Given this list of marker genes QRICH1, EZH2, ACAN, TRPV4, CYP2R1, DDRGK1, B4GALT7, KIF22, FLNA, MATN3, POLR1A, TNFRSF11B, CFAP410, COMP, CHD7 (chromodomain helicase DNA binding protein 7), CUL7, PHEX, PTPN11, NANS, NSMCE2, PTH1R, CENPE, CCN2 (NCBI Gene Id 1490), TCIRG1, NPR2, RPL13, CRTAP, CLCN5, TINF2, EXOC6B, CSPP1, TERC, IL2RG, OCRL, CWC27, EIF2AK3, PLCB3, B3GALT6, GJA1 (NCBI Gene Id 7953), NOTCH3, IFT140, GPX4, EFL1 (elongation factor like GTPase 1), ALG9 (NCBI Gene Id 79796), POLE, SLC39A13, TMEM53, RASA1, LBR, NOTCH2, MAP3K7, EXT2, RNU4ATAC, NEK1, SFRP4, B3GAT3, ADA, LIG4, AMER1, SMAD4, LIFR, CHST3, ACVR1, EXT1, LPIN2, HDAC6, DNAJC21, FIG4, WRAP53, PCYT1A, NPM1, ARCN1, TRIP11, IFT122, BGN, BMP1, CCN6, COL11A1, AIFM1, SLC17A5, RAB33B, COL10A1, KCNE5, RB1, TONSL, DCLRE1C, LMBR1, LRRK1, CANT1, CLCN7 (chloride voltage-gated channel 7), MTAP, ANTXR1, TGFB1, PRKAR1A, SH3PXD2B, ABCC9, VPS33A, GNAS, NSD1, EXTL3, SLC29A3, IDH1, KCNJ8, PRKG2 (protein kinase cGMP-dependent 2), ATP7A, SETBP1, FBN1, ANKH, CTC1, IL7R, BMPR1B, GALNS, PEX7, DYNC2LI1, NHP2, SNRPN, TERT, RMRP (RNA component of mitochondrial RNA processing endoribonuclease), ACP5, IFT172, SNX10, TRPV6, DYNC2I2, RAB3GAP2 (NCBI Gene Id 26114), PISD, CEP120, PTDSS1, HNRNPH1, MAGEL2, TYMS, DNA2, AMMECR1, UFSP2, P4HB, OBSL1, COG4, RAG2, RUNX2, HSPG2, WDR26, ANAPC1, ALPL, IDH2, ALG3, GNPTAB, CTNS, LRP5, EED, DYNC2H1, IFT52, POP1 (NCBI Gene Id 23044), ACSL4, IDUA, CHEK2, COL2A1, ARSB, RAG1, RTL1, TBXAS1, DKC1, AXIN1, GNPNAT1, ERI1, SEC24D, WDR35 (NCBI Gene Id 57539), GSC, PORCN, CDKN1C, KIAA0753, GLB1, TNFSF11, SLC26A2, CSF1R, TTC21B, PARN, TAPT1, OSTM1, SIK3, DYM, MEG3, NKX3-2, ASCC3, INPPL1, PIK3C2A (phosphatidylinositol-4-phosphate 3-kinase catalytic subunit type 2 alpha), RSPRY1, VDR, CCDC8 (NCBI Gene Id 83987), PEX5, FGFR3, CSGALNACT1, SBDS, SLC35D1 (NCBI Gene Id 23169), TP53, CYP3A4, USB1, TRAPPC2, WDR19, STX16, TMEM165, SUZ12, SLC34A3, FN1, NOP10, PDGFRB, CYP27B1, TNFRSF11A, VAC14, MMP2, LONP1, CASR (NCBI Gene Id 846), NDN, PAM16, IFT43, PLEKHM1, NEPRO, SRP54 (signal recognition particle 54), SKI, PDE4D, RTEL1, PCNT, GPC6, KIAA0586, DYNC2I1, COL11A2, SHOX, DLK1, ERCC1, XYLT1, RECQL4, DDR2, IFT80, MMP13, PLOD2, MMP9, IARS2, FAM111A, here is a description of the gene set: Abnormal metaphysis morphology studied in species Homo sapiens An abnormality of one or more metaphysis, i.e., of the somewhat wider portion of a long bone that is adjacent to the epiphyseal growth plate and grows during childhood. Human Gene Set: HP_ABNORMAL_METAPHYSIS_MORPHOLOGY